The following is a description of a gene set: Human Gene Set: DESCARTES_FETAL_LUNG_STROMAL_CELLS The gene expression program underlying the specification of human cell types is of fundamental interest. The study authors generated human cell atlases of gene expression and chromatin accessibility in fetal tissues. For gene expression, the study authors applied three-level combinatorial indexing to >110 samples representing 15 organs, ultimately profiling ~4 million single cells. The study authors leveraged the literature and other atlases to identify and annotate hundreds of cell types and subtypes, both within and across tissues. Our analyses focused on organ-specific specializations of broadly distributed cell types (such as blood, endothelial, and epithelial), sites of fetal erythropoiesis (which notably included the adrenal gland), and integration with mouse developmental atlases (such as conserved specification of blood cells). These data represent a rich resource for the exploration of in vivo human gene expression in diverse tissues and cell types. Marker genes curated from the annotated cluster as represented in the Descartes Human Gene Expression During Development database. from publication Cao J, O'Day DR, Pliner HA, Kingsley PD, Deng M, Daza RM, Zager MA, Aldinger KA, Blecher-Gonen R, Zhang F, Spielmann M, Palis J, Doherty D, Steemers FJ, Glass IA, Trapnell C, Shendure J (PMID 33184181) studied in species Homo sapiens, and this is the list of marker genes: XPNPEP2, FREM1, MIR1245A, ABCA6, CYP27C1 (cytochrome P450 family 27 subfamily C member 1), TDO2, TMEM132C, S1PR3, PHEX, TARID, RSPO2, ZNF385D, HPSE2, ASPA, MTMR12P1, ZNF385D-AS2, FGF7, PDGFRA, MMP23B, SLIT2-IT1, TEX15, FAP, ITGA8, TM6SF2, MIR218-1, PTH1R (NCBI Gene Id 5745), CACNA1C-IT3, VEGFD, LSAMP-AS1, LINC02367, COL13A1, ROR1-AS1, TULP1, MYOCD, PRR16, PGR, MUSK, LAMA2, GABRG3, LINC02497, LUM, FGF10-AS1, OCA2, RGS13, FGFR4, LURAP1L-AS1, KIF25, C2CD6, ENSG00000250378, CACNA1D, AGMO, HSD11B1, SLIT2, ENSG00000231424, BMP5, TRHDE, CACNA1G